The following is a description of a gene set: Human Gene Set: GOMF_GAP_JUNCTION_HEMI_CHANNEL_ACTIVITY A wide pore channel activity that enables the transport of a solute across a membrane via a gap junction hemi-channel. Two gap junction hemi-channels coupled together form a complete gap junction. species: Homo sapiens, and this is the list of marker genes: PANX3, GJA3, GJA1, PANX2, GJA5, PANX1